The following is a description of a gene set: A membrane coat found on a coated vesicle. studied in species Homo sapiens Human Gene Set: GOCC_VESICLE_COAT, and this is the list of marker genes: AP1S3, SEC31B, AP1B1, AP1M2, AP1M1, AP1S1, MYCBPAP, STON2, TBC1D5, EPS15, SAR1A, DIPK2A, AFTPH, COPB2, SGIP1, AP1S2, COPZ1, SEC24C, CLTCL1, SEC31A (NCBI Gene Id 51424), AP1G1, SEC13, SEC24B, SEC24A, SLC18A3, AP2B1, NECAP2, AP2M1, SEC23B, PDCD6, KLHL12, NECAP1, EPN3, AP2A2, CLTC, NCALD, SAR1B, AP2A1, SYNRG, EPN2, STON1, COPZ2, COPB1, SCYL1 (SCY1 like pseudokinase 1), COPG1, CLTB, TMED7, SEC23A, ARCN1, COPE (COPI coat complex subunit epsilon), AP2S1, COPA, ENTHD1, BTBD8, CLTA, PEF1, TMED3, AP1G2, SEC24D, EPN1, CIDEB, CLINT1, COPG2, CLBA1